The following is a description of a gene set: studied in species Homo sapiens Human Gene Set: GOBP_POSITIVE_REGULATION_OF_CARDIAC_MUSCLE_CELL_PROLIFERATION Any process that activates or increases the frequency, rate or extent of cardiac muscle cell proliferation., and this is the list of marker genes: MIR19B1, FGFR2 (NCBI Gene Id 2263), GATA6, ERBB4, MIR204, RBPJ, TGFBR3, MIR199A1, GLI1, MIR222, CCNB1, TBX5, MIR509-1 (microRNA 509-1), FGFR1, PIM1, WNT2, BMP10, NOTCH1, HEY2, FGF9, MIR548C, MIR17HG, MAPK14, ZFPM2, NRG1, MIR590, BMPR1A, YAP1, FGF2, CDK1, MEF2C (NCBI Gene Id 4208), TBX20, TBX2